Given this list of marker genes ECHDC3, CDC14B, DAO, NR1I2, COL18A1, BOK, LECT2, ANGPTL3, CYP2C8, CPT2, UGT1A10, SELENOO, ADH1A, EHHADH, AGXT, BHMT, RUNDC3B (NCBI Gene Id 154661), KCNJ8, ETNPPL, ECM2, SCP2, CYP2J2, SLC22A1, BAAT, CYP4A22, ALAS1, LDHD, ETNK2, CTH, ABCB4, RHOB, CYP4F11, GPLD1 (NCBI Gene Id 2822), TAT, NUDT7, MPDZ, PIPOX, CPB2, FMO4, NAT2, PNPO, GPT, EPHX1, CYP8B1, RORC (NCBI Gene Id 6097), RGN, KNG1, HAGH, PFKFB1, ACADL, LINC01018, ETFDH, HIBADH, C3P1, NECAB2, ABCA6 (ATP binding cassette subfamily A member 6), F8, CYP4F3, MYRIP, CDO1, TST, NR1I3, KLF9, ADH4, AKR7A3, SYTL4, CYP1A2, ACSM5, ABCA8, AADAC, PRAP1, CYP4F2, CLDN14, AOX1, DHTKD1, OTC, CPED1, DEPDC7, MTTP, HSD11B1, MAT1A, F12, CYP4A11, PCK1, CIDEB, GLYATL1, GNE, SLC16A2, MASP2, CCL14, LONP2, GCDH, HPD, HSD17B6, RWDD3, ACYP2, CYP2B6, AR, ABCG8, SERPING1, ST3GAL6, MTHFD1, ALDH3A2, RTP3, NAGS, CA5A, AZGP1, NUDT6, GRHPR, OASL (2'-5'-oligoadenylate synthetase like), RCL1, MYO1B, BLOC1S1, HADH, TTPA, SMIM14, CAT, WNK3, CYP27A1, ACBD4, SERPINA10, SEC14L2 (NCBI Gene Id 85372), CYP2C9, ALDH6A1, ADH6, OGDHL, CYP3A43, ALDH1L1, DCXR, CES2, ABCB11, AQP9, CMBL, HNF4A, GLYAT, GPT2, MLYCD, ECHDC2, ALDH5A1, AGXT2 (NCBI Gene Id 64902), ITIH1 (inter-alpha-trypsin inhibitor heavy chain 1), SLC38A3 (solute carrier family 38 member 3), AFM, PDK4, RDH16, AASS, C6, SLC46A3, SERPINC1, HAO1, GAMT, DHRS1, BHMT2, ABAT (NCBI Gene Id 731754), SLC10A1, BTD, PLG, AMDHD1, TPRG1, APOA5, SULT2A1, CUX2, SULT1B1, RBP5, SELENBP1, TFR2, GYS2, C8A, FMO3, SLC2A2, POR, SLC38A4, SORBS2, ADRB2, HJV, HAAO, CCL16, SYBU, SRD5A1, here is a description of the gene set: Top 200 marker genes down-regulated in the 'proliferation' subclass of hepatocellular carcinoma (HCC); characterized by increased proliferation, high levels of serum AFP, and chromosomal instability. Hepatocellular carcinomas represent the third leading cause of cancer-related deaths worldwide. The vast majority of cases arise in the context of chronic liver injury due to hepatitis B virus or hepatitis C virus infection. To identify genetic mechanisms of hepatocarcinogenesis, we characterized copy number alterations and gene expression profiles from the same set of tumors associated with hepatitis C virus. Most tumors harbored 1q gain, 8q gain, or 8p loss, with occasional alterations in 13 additional chromosome arms. In addition to amplifications at 11q13 in 6 of 103 tumors, 4 tumors harbored focal gains at 6p21 incorporating vascular endothelial growth factor A (VEGFA). Fluorescence in situ hybridization on an independent validation set of 210 tumors found 6p21 high-level gains in 14 tumors, as well as 2 tumors with 6p21 amplifications. Strikingly, this locus overlapped with copy gains in 4 of 371 lung adenocarcinomas. Overexpression of VEGFA via 6p21 gain in hepatocellular carcinomas suggested a novel, non-cell-autonomous mechanism of oncogene activation. Hierarchical clustering of gene expression among 91 of these tumors identified five classes, including CTNNB1, proliferation, IFN-related, a novel class defined by polysomy of chromosome 7, and an unannotated class. These class labels were further supported by molecular data; mutations in CTNNB1 were enriched in the CTNNB1 class, whereas insulin-like growth factor I receptor and RPS6 phosphorylation were enriched in the proliferation class. The enrichment of signaling pathway alterations in gene expression classes provides insights on hepatocellular carcinoma pathogenesis. Furthermore, the prevalence of VEGFA high-level gains in multiple tumor types suggests indications for clinical trials of antiangiogenic therapies. from publication Chiang DY, Villanueva A, Hoshida Y, Peix J, Newell P, Minguez B, LeBlanc AC, Donovan DJ, Thung SN, Solé M, Tovar V, Alsinet C, Ramos AH, Barretina J, Roayaie S, Schwartz M, Waxman S, Bruix J, Mazzaferro V, Ligon AH, Najfeld V, Friedman SL, Sellers WR, Meyerson M, Llovet JM (PMID 18701503) studied in species Homo sapiens Human Gene Set: CHIANG_LIVER_CANCER_SUBCLASS_PROLIFERATION_DN